Given this list of marker genes Cacna2d1, Vash2, Atosb, Myog, Sh2b1, Klhl5 (NCBI Gene Id 71778), Atp1a1, Hes6, Fzd3, Myl4, Chrna1, Tnnc2, Prss23, Lrp4, Bcl6, Hmgcs2, Stam (NCBI Gene Id 20844), Ago2, Celf1, Pbxip1, Cdkn1a, Svbp, Fam241a, Cd82, Pacs2, Vkorc1, Tnnt3, Scrib, Myl1, Anks1b, Pdlim3 (NCBI Gene Id 54428), Stk17b, Kifc3, Tmcc3, Nav2, Lgals4, Klhdc10, Kif5c, Ppfia4, Akt2, Cluh, Rb1, Hs2st1, Hspb8, ENSMUSG00000124599, Tnni2, Myod1 (NCBI Gene Id 17927), Rhob, Cpeb3, Igf2, Hip1, Dysf, Dcakd, Hdac11, Prkar2b, Anxa11, Cfl2, Atp2a1, Hrc, Cpsf6, Acta1, Prnd, Lmnb2, Klf5, Slf2, Gpc1, Gadd45g, Psmc3, Tfrc, Ccnd3, Eno3, Fcer1g, Chrnb1, Dmpk, Gys1 (NCBI Gene Id 14937), Chrng, Runx1, Agpat5, Ckm, Igfbp5, Bin1, Tnnt2, Dbn1, Mybph, Mylpf, Myh3, Plekho1 (NCBI Gene Id 67220), here is a description of the gene set: The activation of muscle-specific gene expression requires the coordinated action of muscle regulatory proteins and chromatin-remodeling enzymes. Microarray analysis performed in the presence or absence of a dominant-negative BRG1 ATPase demonstrated that approximately one-third of MyoD-induced genes were highly dependent on SWI/SNF enzymes. To understand the mechanism of activation, we performed chromatin immunoprecipitations analyzing the myogenin promoter. We found that H4 hyperacetylation preceded Brg1 binding in a MyoD-dependent manner but that MyoD binding occurred subsequent to H4 modification and Brg1 interaction. In the absence of functional SWI/SNF enzymes, muscle regulatory proteins did not bind to the myogenin promoter, thereby providing evidence for SWI/SNF-dependent activator binding. We observed that the homeodomain factor Pbx1, which cooperates with MyoD to stimulate myogenin expression, is constitutively bound to the myogenin promoter in a SWI/SNF-independent manner, suggesting a two-step mechanism in which MyoD initially interacts indirectly with the myogenin promoter and attracts chromatin-remodeling enzymes, which then facilitate direct binding by MyoD and other regulatory proteins. from publication de la Serna IL, Ohkawa Y, Berkes CA, Bergstrom DA, Dacwag CS, Tapscott SJ, Imbalzano AN (PMID 15870273) studied in species Mus musculus Genes up-regulated in NIH 3T3 cells (fibroblasts) 24 h after inducing MyoD differentiation program. Mouse Gene Set: DELASERNA_MYOD_TARGETS_UP